Given this list of marker genes JOSD1, CDPF1, SGCD, ERLIN2, TMEM265, LGI1, PYGO2, CYP24A1, IRF2BP2, PSMC2, PGM2L1 (NCBI Gene Id 283209), STAU1, ZNF197, FTO, MLKL, MGA, RYBP, EEIG2, ADGRE3, TRIM44, MAN1A1, RLIG1, F2R, BNIP3L, ETV1, ATP5MF, TCAIM (T cell activation inhibitor, mitochondrial), VTCN1, S1PR1, DVL3, ERP27, UBE2B, ZNF275, TRAF5, MB21D2, OPALIN, ANKRD17, ATP10D, FNDC1, FBXL17, EFEMP1, ALAS1, GCH1, CRYBG3, TRIM22, PHACTR4, CADM1, SLC25A40, SLC41A2, PATL2, OCRL, BCOR, THAP6, GPX5, NOTCH2, PLEKHA5, EFCAB14, NFASC, CACNA1D, UTP25, IL11, CADPS (NCBI Gene Id 8618), MAL2, NT5E, MBNL2, CTCFL, ZBTB20, PTCHD4, FAM210B, SLITRK1, MYLIP, CHRM5, ITGA2, DARS1, GPATCH2L, ELAVL2, TAB3, TENM1, TBCK, DKK3, DHFR, LYRM7, PCDH9, EPM2A, USP49, here is a description of the gene set: species: Homo sapiens Genes predicted to be targets of miRBase v22 microRNA hsa-miR-3201 in miRDB v6.0 with MirTarget v4 prediction scores > 80 (high confidence targets). from publication Chen Y, Wang X (PMID 31504780) Human Gene Set: MIR3201